The following is a description of a gene set: This event has been computationally inferred from an event that has been demonstrated in another species.<p>The inference is based on the homology mapping from PANTHER. Briefly, reactions for which all involved PhysicalEntities (in input, output and catalyst) have a mapped orthologue/paralogue (for complexes at least 75% of components must have a mapping) are inferred to the other species. part of: Mitotic Prometaphase species: Mus musculus electronically inferred by orthology from the curated human pathway Reactome Pathway: EML4 and NUDC in mitotic spindle formation, and this is the list of marker genes: Cenpt, Cenpm, Cenpa, Tubal3, Mis12, Tuba3b, Xpo1, Clasp1, Cenpn, Dynll1, Dync1li2, Seh1l, Tubb4a, Ska1, Eml4, Tubb6, Kntc1, Cenpq, Itgb3bp, Mad1l1, Ndc80, Spc24, Tuba1b, Zwilch, Kif2b, Nde1, Ndel1, Ppp2r5a, Tuba1c, Tuba1a, Aurkb, Tubb4b, Cenpu, Tubb2b, Ppp2r5d, Tuba4a, Ppp2r5b (NCBI Gene Id 225849), Cenps, Nup133, Plk1, B9d2, Nudc, Nup85, Ppp2r1b, Cenpe, Kif2c, Tuba8, Mad2l1